Given this list of marker genes Pola1, Terf1, H2bc22, H4c3, H2bc7 (H2B clustered histone 7), H4c12, Cenpn, H2ac4, H2ac10, H4c8, Pold4, Hjurp, H2ac6, Pif1, H4c2, Wrap53, H2bc27, H2ac20, Pola2, H2bc11, H2ac1, Chtf18, H2ac11, H2bc9, Ten1, Rbbp4, Itgb3bp, H2ac8, Ppp6c, H2ac13 (NCBI Gene Id 319191), H2ac19 (NCBI Gene Id 319192), Cenpq, Cenpt, H2bc1, H2ac23, Rpa1, Daxx, Ccna1, Pold2, Terf2, Smarca5, H2bc13, Dna2, H2ac22, Shq1, H4c1, H2ac12, Cenpm, Pcna, H4c18, H3f3a, Cenps, H2ac15, H2ac7, H4c17, Wrn, Nop10 (NOP10 ribonucleoprotein), Pold1, Dscc1, Rfc1, Acd, Tert, Rbbp7, H4c6, H2bc3, H4c9, Cenpx, Ctc1, Chtf8, Cenpu (centromere protein U), H2bc15, H2bc8, Oip5, H2ax, H2az2, H2bc12, Npm1, Lig1, H4c4 (H4 clustered histone 4), Blm, Rfc3, H4c11, H4c14, Prim1, H2ac24, Cenpa, here is a description of the gene set: electronically inferred by orthology from the curated human pathway This event has been computationally inferred from an event that has been demonstrated in another species.<p>The inference is based on the homology mapping from PANTHER. Briefly, reactions for which all involved PhysicalEntities (in input, output and catalyst) have a mapped orthologue/paralogue (for complexes at least 75% of components must have a mapping) are inferred to the other species. Reactome Pathway: Chromosome Maintenance studied in species Mus musculus part of: Cell Cycle